The following is a description of a gene set: part of: Drug resistance of FLT3 mutants Crenolanib is a second-generation type I tyrosine kinase inhibitor with activity against FLT3. This pathway describes FLT3 mutants that are resistant to crenolanib-mediated inhibition. species: Homo sapiens Reactome Pathway: crenolanib-resistant FLT3 mutants, and this is the list of marker genes: FLT3